The following is a description of a gene set: The chemical reactions and pathways involving riboflavin (vitamin B2), the precursor for the coenzymes flavin mononucleotide (FMN) and flavin adenine dinucleotide (FAD). Human Gene Set: GOBP_RIBOFLAVIN_METABOLIC_PROCESS species: Homo sapiens, and this is the list of marker genes: FLAD1, RFK, SLC52A3, SLC52A2, SLC52A1